Given this list of marker genes CUL1, PSMC4, TWIST1, ESR1, PSMD8, PSMA4, PPARGC1B, PSMB7, PSMD6, SKP1, HIVEP3, NKX3-2, CBFB, PSMA6, MSX2, RBX1, PSMD14, PSMC6, ADRM1, PSMC5, UBB, PSMD2, SKP2, PSMC1, STUB1, PSMB4, PSMD11, RUNX2 (RUNX family transcription factor 2), PSMD3, PSMD1, PPARGC1A, DLX5, PSMA5, WWP1 (WW domain containing E3 ubiquitin protein ligase 1), PSMB1, PSMB2, PSMD7, PSMA3, PSMD13, SEM1, PSMB6 (proteasome 20S subunit beta 6), PSMA7, DLX6, ESRRA, PSMB3, NR3C1, PSMC2, STAT1, PSMA1, PSMA2, UBC (NCBI Gene Id 7316), RPS27A, PSMD12, GSK3B, PSMB5, UBA52, PSMC3, BMP2, SMURF1, here is a description of the gene set: Human Gene Set: REACTOME_REGULATION_OF_RUNX2_EXPRESSION_AND_ACTIVITY Regulation of RUNX2 expression and activity species: Homo sapiens